Given this list of marker genes HLA-DRB5, IDH3G, ESRP2, UBA7, PARM1, TRIM44, RBMS3, ARRB1, GFRAL (NCBI Gene Id 389400), ASB6, CYTH3, CARD11, SDR42E1, DDRGK1, COMT (NCBI Gene Id 1312), RBPMS, AADACL3, PWWP2A, URI1, BTNL3, GJA10, TMEM244, CUZD1, PPCS, BBOX1, ANXA11, UBE2I, PPP1R15B, TSPAN15, STK40, MAP6, ECE1, ZDHHC7, BAALC, CLVS2, PLEC, TSR2, ZNF317, GORASP1, BCL10, CORO1A, LTB (NCBI Gene Id 4050), SPOCK1, MAP7D2, EIF1P3 (eukaryotic translation initiation factor 1 pseudogene 3), HLA-DOA, VKORC1, RNF167, MVB12A, CAV3, ARMCX4, PRR23B, PGLS, PIGZ, WNK3, DCLK2, TACR1, ANKRD13C-DT (ANKRD13C divergent transcript), CAPN2, RNF152 (NCBI Gene Id 220441, ring finger protein 152), PFN2, PNLIPRP2, HLA-DQA1, MB21D2, ELAPOR2, DIABLO, GOLPH3, CR1L, DERL1, VPS18, TLNRD1, CCDC83, CERS3, NPC1L1, HHLA2, HLA-DPB1, OLAH, SSU72, MBLAC2, GC, NCR3, DDX3Y, LY6S-AS1, SLC36A2 (NCBI Gene Id 153201), TEX14, KRT7, PLP2, PSD4, CD300LD-AS1, MID2, CCND3, STAT6, PNPLA6, HTRA1, ZIK1, SILC1, ADAMTS1 (NCBI Gene Id 9510), HLA-DQB2, TMEM185B, LGALS13, NME8, TTLL1, SVIL, HDX, JAGN1, TMEM200A, BRD2, NTRK2, TMEM18, LINC00299, PHAX, GPX7, RAC2, RFFL, TRIO, OGN, NUAK2, CCDC146, PITHD1, SPEF2, GPR132, QRICH2, NELL2, LMNA, VAPB, WDR93, LUM, FLNA, CD74, FN1 (NCBI Gene Id 2335), SLC25A38, EFS, OR51G1, NPDC1, SLC27A3, STARD8, BHLHE22, PLD6, UNC13C, OTUB1, CABLES2, MKRN9P, ZNF649, SNORD13, SPINK1, SLC8A1, GTF2F1, NIPAL2, NLRP12, SNX12, KL, RAB22A, NDNF, TREML2, CPEB2, GPR141, ID2, ODC1, SCN10A, ARF6, TPPP3, OLIG3, HCRTR2, TMEM9B (NCBI Gene Id 56674), MUL1, RFLNB, LRWD1, GGTLC2, GGTLC1, ZNF24, TMEM199, UBQLN2, LST1, USP12, OR5M8, ZNF501, CES3, SMIM19, SLC15A4, PIN1, DNAJC9, FAM241B, ZFP69 (ZFP69 zinc finger protein), AKR1C4, TPRX1, PON2, RTL8C, SPATA6 (spermatogenesis associated 6), TRIR, SLITRK6, PDPN, ACAA1, MPRIP, VIM, TRIM51, SCAMP2, CUEDC2, PDGFC, here is a description of the gene set: Genes down-regulated in Ly6C low monocytes: untreated versus rosiglitazone. PPARγ is known for its anti-inflammatory actions in macrophages. However, which macrophage populations express PPARγ in vivo and how it regulates tissue homeostasis in the steady state and during inflammation is not completely understood. We show that lung and spleen macrophages constitutively expressed PPARγ, while other macrophage populations did not. Recruitment of monocytes to sites of inflammation was associated with induction of PPARγ as they differentiated to macrophages. Its absence in these macrophages led to failed resolution of inflammation, characterized by persistent, low-level recruitment of leukocytes. Conversely, PPARγ agonists supported an earlier cessation in leukocyte recruitment during resolution of acute inflammation and likewise suppressed monocyte recruitment to chronically inflamed atherosclerotic vessels. In the steady state, PPARγ deficiency in macrophages had no obvious impact in the spleen but profoundly altered cellular lipid homeostasis in lung macrophages. Reminiscent of pulmonary alveolar proteinosis, LysM-Cre x PPARγflox/flox mice displayed mild leukocytic inflammation in the steady-state lung and succumbed faster to mortality upon infection with S. pneumoniae. Surprisingly, this mortality was not due to overly exuberant inflammation, but instead to impaired bacterial clearance. Thus, in addition to its anti-inflammatory role in promoting resolution of inflammation, PPARγ sustains functionality in lung macrophages and thereby has a pivotal role in supporting pulmonary host defense. Human Gene Set: GSE32034_UNTREATED_VS_ROSIGLIZATONE_TREATED_LY6C_LOW_MONOCYTE_DN from publication Gautier EL, Chow A, Spanbroek R, Marcelin G, Greter M, Jakubzick C, Bogunovic M, Leboeuf M, van Rooijen N, Habenicht AJ, Merad M, Randolph GJ (PMID 22855714) species: Homo sapiens